Given this list of marker genes FZD2, ARPIN-AP3S2, NKD2, TMEM262, C7, LRP3, LINC00562, SNORD116-30, INTS5, GRINA, LINC01686, LENG1, ABHD13, SF3B2, CNRIP1, CXCL12, WDR97, PNRC1, NPM3, RPP25, CYP51A1P2, RPL27P6, GPS2, MRGPRF, VCAM1, RPL10AP2, BAZ1A-AS1, LINC01350, RPL13AP3, MICALL2, SET, TCF3, HASPIN, LINC02610, SPIC, TP53BP2, ZNF665, TYRO3, EFEMP2 (EGF containing fibulin extracellular matrix protein 2), NFKBIA, IRF2-DT, NPB, LINC02228 (NCBI Gene Id 105374694), UBD, ENSG00000246308, STX10, MAP3K6, WWTR1-AS1 (NCBI Gene Id 100128025), TENT5D, PJVK, RPL7P12, THAP5P1, TRIM47, NALF2, NPIPA1, NRIP2, TEX12, FGF7, SOCS3, NFIL3, RPL21P68, CPSF4, MTNAP1, ADAMDEC1, PRRX1, RPL31P4, LINC00654, FAM3C2P, TMPRSS12, FBXW5, PHF24, C11orf68, UBAC2-AS1, GAD3P, GTF2F1, GPANK1, PARK7, COMMD2, PTGDS, ALDH1A3-AS1 (ALDH1A3 antisense RNA 1), SNHG11, ATOX1, ZNF140, C1GALT1C1L, CTDP1-DT, RPLP1P6, CCDC28B, PPIL3, RASGEF1A (NCBI Gene Id 221002), CR2, RPL3P7, IGFN1, CSF1, HMCN2, NFKBIZ, KCNK15 (potassium two pore domain channel subfamily K member 15), PABPC5, CCL2, NFKB2, DAZL, IER3, TMEM147-AS1, EIF5-DT, OTOP2, UBR7, BAD, GDF6, FDCSP, LINC02126, IFIT2, PES1, LERFS, WAC-AS1, RPL7AP47, ZBED6, VEGFA, RPS3P3, LINC02847, HAFML, ENSG00000257550, ISOC2, IFI27L2, ALX3, ZFP36L2, TECRP1, COL6A5, EGR1, PI15, ITPR1-DT, RARA-AS1, PSMG3 (NCBI Gene Id 84262), LPAR1, EIF4BP3, SPIN2A, SCARF2, TNFAIP3, SNX33, TYMP, SCYL1, FOS, TNFSF9, MSANTD1, FKBP9P1, ICAM1, JUND, RPL7P23, SHISA3, SLC22A3, JMJD4, RAB13 (RAB13, member RAS oncogene family), RPS27AP5, H2AC20, KRTCAP2, SMU1, RELB, ZNF853, P2RX2, FGF11, NOP53, RPL5P12, CCNI, PLSCR3, ZNF17, AARD, ARL6IP4, RIN1, NME2, SF3A3, LINC01786, RNU6-1330P, LARP6, EFTUD2, ENSG00000226706, RPS18P5, ENSG00000223834, CTSH, SPNS2, YY2, CNOT10-AS1, LIPT1, ZNF335, ADM2, ENSG00000261327, SCGB1B2P, RPL35P2, PDRG1, RGS16, DERL1, UBQLN2, FUT4, AHDC1, ATP2A1-AS1, RPL17P36, PI4K2A, NFKBIE, LINC01787, AGAP2-AS1, CTSF, HECTD3, TMEM18, RPL23AP65, SELENOM, NYNRIN, ADH1B, IL11RA, SSU72-AS1, TNFSF11, VPS16, FNDC1-AS1, HOXC-AS1, RPL36P14, RBP5, FLJ40288, ENSG00000257279, MIF, HNRNPUL2, PCDHGA3, BCL3, RPS3P4 (ribosomal protein S3 pseudogene 4), HDAC4-AS1, MINCR, LINC00852, RBBP9, HLA-J, RPL10P16, ZFP64, ZGPAT, MSC, ALG1L13P, CD109-AS1, SPOUT1, TRMT6, RIOX2, RNU1-149P, RPS12P32, HTD2, KCNE4, PSMB1, IGDCC4, PABPC3 (NCBI Gene Id 91297), GARS1, TLCD1, RPS8P10, CXCL13, ASH1L-AS1, HOXA2, SEPTIN7P6, RPL5P34, ANKRD29, FAM133DP, LAP3, MLF1-DT, HNRNPA0, C1S (NCBI Gene Id 716), SERTAD1 (NCBI Gene Id 29950), KPNA2P2, RPL10P3, GLI4, MIR3677HG, SF3A2, CDC7, RPS17P16, LINC01311, EIF2AK3-DT, LRRC37A17P, CDC42P6, KCND1, JUNB, TPBGL, LINC00324, EFCAB10-AS1, SMARCAD1-DT, LINC00310, BARX1, ZNF500, CIAPIN1, C1orf35, RAI2, RPS3AP21, here is a description of the gene set: Human Gene Set: DESCARTES_MAIN_FETAL_CCL19_CCL21_POSITIVE_CELLS The gene expression program underlying the specification of human cell types is of fundamental interest. The study authors generated human cell atlases of gene expression and chromatin accessibility in fetal tissues. For gene expression, the study authors applied three-level combinatorial indexing to >110 samples representing 15 organs, ultimately profiling ~4 million single cells. The study authors leveraged the literature and other atlases to identify and annotate hundreds of cell types and subtypes, both within and across tissues. Our analyses focused on organ-specific specializations of broadly distributed cell types (such as blood, endothelial, and epithelial), sites of fetal erythropoiesis (which notably included the adrenal gland), and integration with mouse developmental atlases (such as conserved specification of blood cells). These data represent a rich resource for the exploration of in vivo human gene expression in diverse tissues and cell types. studied in species Homo sapiens from publication Cao J, O'Day DR, Pliner HA, Kingsley PD, Deng M, Daza RM, Zager MA, Aldinger KA, Blecher-Gonen R, Zhang F, Spielmann M, Palis J, Doherty D, Steemers FJ, Glass IA, Trapnell C, Shendure J (PMID 33184181) Marker genes curated from the annotated cluster as represented in the Descartes Human Gene Expression During Development database.